Given this list of marker genes TMEM178A, VIT, SLC30A6, ENSG00000287255, ENSG00000236854, BIRC6-AS2, CYP1B1-AS1, CRIM1-DT, RNU6-951P, MIR558, SLC8A1-AS1, RPL7P12, LINC01883, LINC01318, SOS1-IT1, HSPE1P13, FEZ2, PRKD3-DT, RNU6-198P, HNRNPA1P57 (NCBI Gene Id 101060039), H2ACP2, RPL31P16, RPLP0P6, RNA5SP91, CDKL4, LINC01946 (long intergenic non-protein coding RNA 1946), RPL21P36, CRIM1, LTBP1, LINC01794, KRT18P52, NDUFAF7, SPAST, QPCT, CDC42EP3-AS1, HNRNPA1P61, THUMPD2, RNU6-1117P, RNU6-647P, CEBPZ, RNU6-1116P, MRPL50P1, FAM98A, CEBPZOS, RN7SL96P (RNA, 7SL, cytoplasmic 96, pseudogene), MAP4K3-DT, RNU6-577P, SLC30A6-DT, NLRC4, SLC8A1, MIR548AD, RNU6-851P, DDX50P1, ARL14EPP1, CDC42EP3, YIPF4, TTC27, RACK1P2, PRKD3, SOS1, ATP6V0E1P3, ATL2, LINC02613, NPLP1, STRN, TTC39DP, MIR4765, RMDN2-AS1, MIR4430, SLC25A5P2, LINC01320, MEMO1, SMIM7P1, MAP4K3, MYADML, BIRC6, RMDN2 (NCBI Gene Id 151393), SRSF7, ARHGEF33 (NCBI Gene Id 100271715), ENSG00000237320, RN7SL602P, ENSG00000269210, BIRC6-AS1, GPATCH11 (G-patch domain containing 11), GAPDHP25 (NCBI Gene Id 391367), HEATR5B, DPY30, DHX57, PIRAT1 (NCBI Gene Id 101929559), SULT6B1, AK2P2, MORN2, RNA5SP92, GEMIN6, ASS1P2, GALM, LINC00486, EIF2AK2, RNU6-939P, RASGRP3, HNRNPLL, CYP1B1, here is a description of the gene set: studied in species Homo sapiens Human Gene Set: chr2p22